Given this list of marker genes Creb1, Pnkd, Ptbp3, Myc, Flcn, Faf1, Gpr50, Iqgap2, Rgs7bp, Scrt2, Vps13d, Lcp1, Hdhd5, Aifm3, Tmem151a, Insm1, Araf, Ncan, Casp9, Trib2, Slc30a6, Lrrc32, Yeats4 (NCBI Gene Id 75922), Txnip, Pappa, Corin, Rnf4, Sardh, Epha6, Kcna6, Fabp3, Mycbp2, Natd1, Wdr76, Cbfa2t2, Efnb3, Man2a2, Fzr1, Mif4gd, Lmbr1l, Nt5e, Sgk3, Rps6ka4, Ywhaz, Ablim3, Tlk2, Celf4, Plxna2, Strada, Ahr, Cbx5, Nrip2, Akr1b1, Nrf1, Fntb, Iigp1, Arhgap21 (NCBI Gene Id 98793), Elf2, Add2, Cobl, 5031439G07Rik, Ust, Mid1, Pde7a, Lias, Lrrc7, Vcl, Fbxo27, A430033K04Rik, Cimap1c, Epha4, Ttc19 (tetratricopeptide repeat domain 19), Mtfp1, Ly6e, Kif3b, Ttn, Bcl9l, Stk35, Rmi2, Cacna1d, Otud7a, Serpinh1, Cyp2b23, Tmem179, Stc1, Ndfip2 (NCBI Gene Id 77152), Gnpda1, Cd3e, Mroh1, Mrgprx2, Fcho2, Mtcl1, Gk5, Ksr2, Kpna3, Adamtsl5, Ark2c, Znrf3, Map3k9, Plxna4, Cercam, Scn2b, Apol7a, Plekhd1, Erf, Crkl, Dlgap1, Aff1, Onecut3, Slc25a32, Fem1a (NCBI Gene Id 14154), Apol7c, Sptbn2, Cdh7, Pald1, Gpr157, Mrgprb1, Rrp1b, Ikbip, Cyp8b1, Ndst1, Lrrc3, Fam83h, Eme1, Bpifb3, Mideas, Kif2b, Sec22b, Rab1b, Mtr, Pax9, Prr3, Htra3, Armc9, Serp1, Dixdc1, Sephs1, Ypel2, Pgap4, Mau2, Cobll1, Tubb5 (tubulin, beta 5 class I), Cntn2 (NCBI Gene Id 320300), Spata18, Serpina3g, Gsdma (gasdermin A), Syt15, Zfp865, Ccp110, Vapb, Specc1 (sperm antigen with calponin homology and coiled-coil domains 1), Stox2 (storkhead box 2), Gpr153, Neu1, Cemip, Crtc1, Nfasc, Zfp282, Zfp398, Pdxk, Vtcn1, Scube1 (signal peptide, CUB domain, EGF-like 1), Thbs1, Mtmr12, Kmt2a, Cyth4, Xrcc2, Usp5, Dgka, Lpar2, Coro2b, Wscd1, Slc25a37, Fgf18, Srsf2, Ctnnd1, Elmod1, Map4, Stk39, Rnase1, Pcsk5, Usp13, Sh2b3, Samd8, Kcnk4, Psmb11, Ly9, Gga2, Ccl9, Socs7, Leng8, Sema3f, Tpbg, Prelid3a, Iqsec2, E2f6, Mapkbp1, Kcna2, Creb5, Cep72, Kdm4b (lysine (K)-specific demethylase 4B), Cacna1e, Tns3, Ergic1, Cyth1, Lnpk, Scara5, Ldlrad2, Cdkn1b, Stk40, Mtcl2 (NCBI Gene Id 98949), Tspan31, 1600014C10Rik, Kdm3b (NCBI Gene Id 76106), Caprin2, Arhgap1, H13, Zfp560, Gabra1, Pnma2, Mrpl15, Ghdc, Vmn2r89, Fam107a, Tbc1d2b, Iqce, Ndel1, Lrp6, Ralbp1, Nav1, Txlng, Klhl9, Eepd1, Mob3b, Gdpgp1, Slc17a7, Ces4a, here is a description of the gene set: from publication Chen Y, Wang X (PMID 31504780) Genes predicted to be targets of miRBase v22 microRNA mmu_miR_709 in miRDB v6.0 with MirTarget v4 prediction scores > 80 (high confidence targets). Mouse Gene Set: MIR_709 species: Mus musculus